The following is a description of a gene set: Mouse Gene Set: chrXF4 studied in species Mus musculus, and this is the list of marker genes: Gm15204, S100g, Gm6568, Gm15195, Sh3kbp1, Phex, Gm15186, Bend2, Yy2, Gm26007, Gm15190, Rs1, n-R5s13, Gm8682, Nhs, Gm15206, Gm15173, Mbtps2, Cdkl5 (cyclin dependent kinase like 5), Gm8648, Gm8737, Gm8659, Gm15169, Gm15189, Gm15196, Gm15170, Gm15172, Gm15201, Prkaca-ps1, Gja6, Map3k15, Gm24281, Syap1, Gm22522, Gm22294, Scml1, Scml2, Gm8644, Gm15212, Map7d2, Txlng, Gm23404, Gm8662, Ppef1, Eif1ax, Smpx, 4930503H13Rik, Gm15193, Grpr, Gm15209, Rps6ka3, Gm7312, Cnksr2, Gm7199, Gm5419, Gm5764, Gm15241 (predicted gene 15241), Gm7331, Phka2, Reps2, Adgrg2, Pdha1 (pyruvate dehydrogenase E1 alpha 1), Gm16459, Gm15163, Rai2, Bclaf3, Ctps2, Sms, Gm15187, Klhl34, Mir3473a, Rbbp7, Gm23786, Gm23901, Gm1947, Gm25795, Gm15171